Given this list of marker genes NEUROD6, PLEKHA1, IGLJ3, EVI2B, AHNAK, INTS11, PTGIS, AP2A1, CACNG4, COA8, NUP107, MGA, NUDT22, IGHM, ZNF266, WWC3, here is a description of the gene set: Human Gene Set: MODULE_547 studied in species Homo sapiens Genes in the cancer module 547.